Given this list of marker genes WDR45, ZFYVE1, WIPI1, WDR45B, NRBF2, BECN1, PIK3R4, WIPI2, ATG14, PIK3C3, here is a description of the gene set: Autophagy-vesicle nucleation/elongation/maturation, PI3P synthesis by PI3KC3-C1. Pathway ID: N01715. Pathway type: Reference. Pathway class: nt06532 Autophagy. Human Gene Set: KEGG_MEDICUS_REFERENCE_AUTOPHAGY_VESICLE_NUCLEATION_ELONGATION_MATURATION_PI3P_SYNTHESIS_BY_PI3KC3_C1 Pathway Definition from KEGG: PI -- PI3KC3-C1 -> PI3P -> (WIPI,ZFYVE1) studied in species Homo sapiens